The following is a description of a gene set: species: Mus musculus Genes positively differentially expressed in cell type: Monocyte upon treatment with cytokine: IL-4 in mouse lymph nodes in vivo. Mouse Gene Set: CUI_MONOCYTE_IL4_RESPONSE_UP from publication Cui A, Huang T, Li S, Ma A, Pérez JL, Sander C, Keskin DB, Wu CJ, Fraenkel E, Hacohen N (PMID 38057668) Cytokines mediate cell-cell communication in the immune system and represent important therapeutic targets. A myriad of studies have highlighted their central role in immune function, yet we lack a global view of the cellular responses of each immune cell type to each cytokine. To address this gap, the authors created the Immune Dictionary, a compendium of single-cell transcriptomic profiles of more than 17 immune cell types in response to each of 86 cytokines (>1,400 cytokine-cell type combinations) in mouse lymph nodes in vivo. A cytokine-centric view of the dictionary revealed that most cytokines induce highly cell-type-specific responses. For example, the inflammatory cytokine interleukin-1β induces distinct gene programmes in almost every cell type. A cell-type-centric view of the dictionary identified more than 66 cytokine-driven cellular polarization states across immune cell types, including previously uncharacterized states such as an interleukin-18-induced polyfunctional natural killer cell state., and this is the list of marker genes: Adam8 (a disintegrin and metallopeptidase domain 8), Tnip3, Casp6, Mrc1, Ahnak, Ccl24, Batf3